The following is a description of a gene set: Human Gene Set: MXD1_TARGET_GENES species: Homo sapiens Genes containing one or more binding sites for (MXD1) in their promoter regions (TSS -1000,+100 bp) as identified by GTRD version 20.06 ChIP-seq harmonization. from publication Yevshin I, Sharipov R, Kolmykov S, Kondrakhin Y, Kolpakov F (PMID 30445619), and this is the list of marker genes: RIMKLB, IK, ERLIN1, HS2ST1, WEE1, CFDP1, TOMM20, MAGOHB, PLAC8, RNU7-29P, LRRC41, PWP1, KCTD20, ZNF778, SRP72, MAST4 (microtubule associated serine/threonine kinase family member 4), PPM1J, RPL31, SLC25A25, C5orf15, STIM2, SUB1, HARS1, SRP14, ZBED3 (zinc finger BED-type containing 3), SPATA1, GCN1, PCNP, LARP7, MMS22L, SNHG4, INTS12, LINC01730, PRKAR1A (NCBI Gene Id 5573), YARS2, FBXO38, C1orf74, SHC4, SPINK13, DUSP28, NUB1, EIF4E, PAIP2, KDM4B, ERI1, GDF15, AGBL5, RNU12, RN7SK, CNOT2, SLC38A11, USP53, CKLF-CMTM1, HNRNPH3, MIR4258, POLE3, G3BP2, NAA15, CHRNB1, NEAT1, INTS9, RNU6-433P, CHMP4C, MOCS2, SETD9 (SET domain containing 9), YAE1, CAPRIN2, GOLPH3L, CABLES1, FAM227A, NAIF1, PSPH, SLC35G1, KTI12, NAMPT, POC1B, SNAP23, RASGRF2, GABPB1-AS1, SMAD5, TRAF3IP2, AKAP9 (NCBI Gene Id 10582), SMTN, SNORD104, PTPA, MLLT3, NIPBL, BLOC1S6, ERCC6, NFKB1, IMMT (NCBI Gene Id 10989), ZNF217, IDH3B-DT, ENO1, ABCB1, GRPEL2, FAM47E, TAF15, TTI2, DUSP6 (dual specificity phosphatase 6), ORMDL1, CSDE1, JMJD1C, MRRF, CCNH, ZNF425, SEC31A, SNORD27, KDM2A, R3HDM1, EPCAM-DT, RBM7, CLCN3, NFKBIZ, CTNND1, MIR181A1HG, SPPL2A, RNU5A-1, CENPP, BTG3-AS1, C11orf71, KIAA1191, METTL8, PIN4, CAPZA1, LDLR, EHF, ZRANB3, SLC38A6, SEC23B, UTP20, H4C5, CPLANE2, RPL22L1, RPS27L, RNU5E-6P, DDX42, NDUFC1, SKAP2, NUDT3, FOXN2, DPP9, PSMC2, CCDC107, UBE2D3, TMEM237, GATAD1 (NCBI Gene Id 79636), RN7SL181P, PPP1R15B-AS1, SNORD118, PEX2, MSL2, TRAM2-AS1, ZSCAN5A, TNPO1, ARRDC3, ESF1, TBC1D19, LMO7, CSNK1G1, CDKN1B, CCDC47, KRIT1, NPM1P26, LINC01058, NSMCE3, USP54, SNORD12C, MRPS30, HNRNPH1, JUP, SNHG25, POLR2A, TNRC6B, RPL4, SLC3A2, INCENP, PIGB (phosphatidylinositol glycan anchor biosynthesis class B), H3C6, RMRP, NEK9, AGR2, AKIRIN2, MGC32805, SH3RF2, CLTC, SGTB, PJA2, NDUFAF5, ASPM, TMEM141, GCNT3, LARS1, CUL2, OPA3, MED16, ATP10B, FAM81A, NBEAL1, SNRPE, MCCC1, GARS1, ANP32B, LINC01623, MAD2L1, ATF7-NPFF, CAPN7, CTDSPL, IMP4, MUC13, PREPL, PPIA, ALG1, DBF4B, EIF4A2, USP8, PPIH, WDFY3-AS2, GNG5, FCHO2, DDX60L, CBFB, COMMD10, BBS4, ARMH4, GABPB1, GHET1, CCNG1, GAS5, ZNFX1, GNAI3, SART3, MTUS1-DT, EIF2S1, C4orf36, CSNK1A1, KMT2E-AS1, NDUFS1, KDM4C, UMPS, SNHG8, RNU6-9, VWA8, RNASE11, ISCU, RRP12, THAP9, ERGIC2, RHOV, DDX21, PPP1CB, MALSU1, PRRG4, PURB, NCOA7, DCAKD, FAM13A, MAD2L1-DT, MMACHC, BOD1, RBM33-DT, TMX3, IL20RA, CSNK1G3, AXDND1, HSPA8P3, PANK3, MFAP3, TRABD2A, VAC14, CDC14A, NSA2, VPS41, IPO7, HOXA-AS3, WDR89, EPC1-AS2, TPT1, CLASP1, HINT1, TRMT13, SECISBP2, TMEM241, RBM19, ENSG00000267882, SHC1 (NCBI Gene Id 6464), CENATAC, DNMBP, SRP54-AS1, SERPINB5, FKBP14, SNHG1, PSME2P3, NARF-AS2, TMF1, DNAJB11, LINC01806, CHAMP1 (NCBI Gene Id 84453), CCNB1IP1, H1-12P, CHASERR, MFN1, POU2F1 (NCBI Gene Id 7823), MIR3189, MRPS30-DT, HSP90AB1, PPP2R2A, LINC02363, TRIM37, KIF16B, EEF1B2, CDV3, MCTS1, ELAC1, NCAPD2, BMP4, LINC02474, SLC39A9 (NCBI Gene Id 55334), HOXB6, MAN2A1-DT, LIMA1, DHX8, CLNS1A, NDUFA2, SNORD45B, ZKSCAN3, H4C16, ATG12, IMMP1LP1, PRELID2 (PRELI domain containing 2), MIR3684, ZFP1, BHLHE41, NUP35, RABGGTB, ZSCAN5A-AS1, PTGES3, ATP5F1B, ATG14, TMEM30A, SCLT1, TMEM126A, RBBP4, TMEM68, ZNF239, CBY1 (NCBI Gene Id 25776), ACAA2, MYO1E, SNORD72, PCNX4-DT, MAN2A1, FERMT1, CAAP1, SBNO1-AS1, FAM114A2, MARVELD2, SPINK5, ZNF627, YJU2, COL17A1, MSI2, CMSS1, LRBA, LMAN2L, RPL23AP95, WDR55, CLIP1, CREBRF, RNU6-2, ZBTB37, MAB21L3, STK40, ATP6V1D, ZWILCH, DTD2, LINC00963 (long intergenic non-protein coding RNA 963), SKIC3, RAB33B, SASS6, PITX1-AS1, LINC02068 (NCBI Gene Id 105374219), SNORA50C, SUPT7L, TK2, RANBP2, CEP63, SLC4A1AP, PPP1R12B, SP110, RNY3, UQCRQ, PITX1, LSM8, RPS13, SF1, RPL21, TIMMDC1-DT, XPO5, ALG9, CNOT3, ANKRD17, HYI, MCCC2, UTP25, SRP54, TMEM62, STRIP1, TSNAXIP1, HOMER1, ZNF25-DT, LNCTAM34A, PWWP2A, TIMM9, RPS15A, HNRNPU, KBTBD2, PLEKHA8, MALAT1, ZNF775, MFSD11, NPTN, RNY1, DCAF17, RNU5E-4P, MRPL51, OSBP, TBXAS1, MOSPD3, CENPN, DNAJC2, CKAP2, HSPD1, NAT10, APOL2 (NCBI Gene Id 23780), GTF3C2-AS2, CCT6A, BRAF, HEATR1, ZFC3H1, USP3, NUFIP2, IRF2BP2, FAM151B-DT, BAZ2B-AS1, ERCC1, GOLGA5, TPM1-AS, HAVCR2, DNAJC3, OTUD4, EID1, RNU5D-1, FIP1L1, MRPS33, SLC50A1, FBXW11, TRAF7, ITGA6, GTF3C6, SRI, ELF1, LINC02889, HILPDA-AS1, CD274, MOCS2-DT, THAP2, AGBL5-AS1, TRAPPC6B, ARSK, YEATS4, RAB14, SAMTOR, COMMD4, HNRNPAB, CCNL1, RANBP10, NIFK-AS1, BTAF1, GRB2, HEG1, CLDND1, KLF5, NDUFAF7, PLPP1, PSMA3-AS1, PNISR-AS1, C16orf95, KRR1, HEATR5B, SESN1, RPL37A, NFATC3, RACK1, SSBP1, ZRANB2-DT, LINC00938, REXO5, WDR20, NBAS, RPS6, ENSG00000249236, TFB1M (transcription factor B1, mitochondrial), H3-3B, LSM5, FBF1, ZBED3-AS1, ATF7, AK2, EFCAB14, HILPDA, MATR3, ZBTB8OS, CALU, UBC, POLH, ALKBH1, COX6B1, MAST4-AS1, KDM1A, ERI2 (ERI1 exoribonuclease family member 2), TBCCD1, AGL, RPRD2, CASP8, ST7L, YTHDF2, UEVLD, FZD1, HIBADH, GULP1, ZGRF1, HIGD2B, GDF9, POLDIP3, ATP5MC3, AHR, CCDC90B, GSTA4, NRBF2 (NCBI Gene Id 91155), DCAF13, MST1L, ALDH1A2, EEF1A1, IPP, DDX39B, CEP57L1, TEX9, LRP10, IWS1, REEP3, STIM2-AS1, EIF3H, GFM2, NEDD4L, CYP2R1, RAB27A, NFIA, CENPW, WEE2-AS1, FAM13B-AS1, MIR760, GPATCH11, PFAS, ENSG00000255647, VTRNA1-2, H3C1, MSANTD3, RCC2, ZBTB4, ELOF1, SENP2, NOL6, ADSL, WBP11, CKS1B, ZFAS1, MMADHC-DT, SMC2, USO1, IDH3B (isocitrate dehydrogenase (NAD(+)) 3 non-catalytic subunit beta), CD164, NLN, ZNF25, DUSP16, CKLF, TMEM259, C3orf49, TTC19, ZNF354B, SRP14-DT, UNK (NCBI Gene Id 85451), VTRNA1-1, NDUFB6, PPP4R3B, SH3PXD2A-AS1, FER, ERH (NCBI Gene Id 95660), UFC1, ZNF747, PPIB, NRL, DUT, TADA1, CRAT (NCBI Gene Id 1384), SNORD13, SMC2-DT, RPL37A-DT, CDS2, RPL35AP36, EGLN2, SATB2, TIAL1, CLDN4, LMAN2, RIMOC1, ARID4A, ITM2B, UBR4, CEP120, HMBOX1, METTL3, TIRAP-AS1, PPFIBP2, NARF, MIA2-AS1, NFU1, MED7, POM121, PMS1, SNAPC5, RPL37, MRPL48, KIAA0586, MAPK14, UACA, DROSHA, SNORD28, CCDC115 (NCBI Gene Id 84317), PPM1D, TIMMDC1, GTF3C2, PLS1, BCAR3, HINFP, PRR13P5, CCDC163, UQCRH (ubiquinol-cytochrome c reductase hinge protein), NOL8